The following is a description of a gene set: species: Homo sapiens Human Gene Set: CUI_DEVELOPING_HEART_C5_VALVAR_CELL from publication Cui Y, Zheng Y, Liu X, Yan L, Fan X, Yong J, Hu Y, Dong J, Li Q, Wu X, Gao S, Li J, Wen L, Qiao J, Tang F (PMID 30759401), and this is the list of marker genes: SNHG12, DSEL, PAMR1, TUBA1A, GOLIM4, LSAMP, CD200, NFATC1, AHR, SERPINF1, B4GALT1, VCAN, PTHLH, NFE2L2, IL33, UCHL1, RHOU, ZFAND2A, ARF4, ARL6IP1, SNHG5, LTBP4, SYNPO2, APOE, PXDN, TSPYL2, HS3ST1, GADD45B, SNAI1, HES1, SELENOM, NRCAM, IER3, PENK, ZFAS1, ENAH, SRPX, EGR2, HAPLN1, TUBB2B, GNG2, DNAJA1, ZBTB20, HSPA1A, ADAMTS19, NR4A1, ZC3HAV1, NR4A2 (nuclear receptor subfamily 4 group A member 2), GLT8D2, APCDD1, EIF4A3, TMEM132C (NCBI Gene Id 92293), TIMP3, ASPN, ATF3, BAG3, TUBB2A, DKK2, CD9, NXF1, NEDD9, MFAP4, CTSK, HSPA7, SERPINB1, MMP19, PPP1R10, EGR1, DYNLT3, TPBG, KLHL15, ECRG4, ID1 (inhibitor of DNA binding 1), TGFB3, ID2, CLU, RGS3, FMOD, BEX1, ZC3H12A, NFIX, FHL1, SPOCK3, XBP1 (X-box binding protein 1), SCRG1, ACTN1, DNAJB1, LMCD1, PPP1R15A, MATN2, ENSG00000286190, RGS4, CD55, ARID5A, SOX9, RNU6-2, AEBP1, CHPF, ADIRF, S100A10, CXCL1, CCDC80, TOB1, CLIC3, ERBB3, LTBP3, PTPRZ1, HEY2, BTG2, MXRA5, SRSF7, LIMA1, ADAMTS1, MYH10, TRPS1, SERPINI1, OAT, GOLM1, THBS1, CADPS, LTC4S, FAT4, PLPP3, LTBP2, FAM114A1, BGN, DNAJB4, PRRX1, CLDN11, CMTM6, CTNNAL1, IGFBP5, IFI6, ID3, SOCS3, CDO1, PDLIM3, SLN (sarcolipin), CRYM, NTRK2 (NCBI Gene Id 4915), MT2A, LIMCH1, C11orf96, S100B, EDIL3, UAP1, NSG1, IRF1, TCEAL7, GEM, IFI27, ID4, VTRNA2-1, SLFN11, SFRP4, SERTAD1, TUBB3, ROBO1, CXCL2, HSPA6, CYP1B1, JUNB, DPYSL3, RASL11B, C1QTNF1, UGDH, ELN, RGS5, SLC22A3, LGALS1, FIBIN, MGP, HSPH1, IGF1, FILIP1L, CHMP1B, ERRFI1, PAPSS1, SALL3 (NCBI Gene Id 27164), HSPA2, S100A6, FOS (NCBI Gene Id 2353), CSRNP1, EIF5, TCF12, MAFF (MAF bZIP transcription factor F), EGR3, CDKN1A (cyclin dependent kinase inhibitor 1A), TNFRSF19, TAGLN, IFRD1, SOX4, PRELP (NCBI Gene Id 5549), TWIST1, TSC22D1, RARG, RNASE4, ITM2A, HSPA1B, LMNA, PTGS2, PLXDC1, TNFAIP6, IER2, CCNL1